The following is a description of a gene set: Any process that stops, prevents, or reduces the frequency, rate or extent of alpha-beta T cell activation. species: Mus musculus Mouse Gene Set: GOBP_NEGATIVE_REGULATION_OF_ALPHA_BETA_T_CELL_ACTIVATION, and this is the list of marker genes: Hmgb1, Socs5, Irf1, Bcl6 (NCBI Gene Id 12053), Adora2a, Anxa1, Runx1, Smad7, Cd69, Twsg1, Itch, Cd300a, Lgals9, Il2, Rc3h2, Tbx21, Xcl1, Zfp35, Vsir, Runx3, Gli3, Hlx, Il4, Pf4, Foxp3, Tnfsf4, Rc3h1, Ihh, Cbfb, Cblb, Jak3, Cd274, Loxl3, Lgals1, Tnfsf18, Il4ra, Zc3h12a, Btla, Tnfrsf14, Cd44, Clec4g, Arg2, Dapl1 (death associated protein-like 1), Tarm1, Slc4a2, Ascl2, Hfe, Zbtb7b, Ndfip1, Socs1, Shh